The following is a description of a gene set: species: Mus musculus Mouse Gene Set: MIR_6935_5P from publication Chen Y, Wang X (PMID 31504780) Genes predicted to be targets of miRBase v22 microRNA mmu_miR_6935_5p in miRDB v6.0 with MirTarget v4 prediction scores > 80 (high confidence targets)., and this is the list of marker genes: Brpf3, Plpp6, Ppp4c, Limch1, Fam89b, Tbr1, Xylt2, Slco1a5 (NCBI Gene Id 28245), Eya1, Atg10, Marf1, Vash2, Acsf2, Grb10, Sfmbt2, Cntn4, Ttc7, Vps25, Slc2a4, 4933428G20Rik, Kdm2a, Zmiz1, Lyl1, Ezh1, Bptf, Tbc1d14, Krtap4-2, Cd37, Fbxw9, Yif1b, Bbln, Pklr, Shisal1, Atf6, Myef2, Fam53c, Git1, Mbnl3, Hpcal4, Acer2, Trpc3, Phc2, Tcte1, Psg21, Prss32, Wars1, Grik3, C2cd2l, Dnajb13, Gm867, Igf2bp2, Dagla, Psg22, Xirp1, Scn4b, Fev, Gars1 (glycyl-tRNA synthetase 1), Wnt1, St8sia6, Cry2, Ttc9, Cyp4v3, Dlg4, Ywhaz, Psg26, Krtap4-6, Ldb3, Brcc3, Ctsw, Sftpa1, Tnfsfm13, Trp53inp2, Psg19, Cdk6, Psg17, Adamts17, Ap1g1, Slc26a5, Arhgef2, Adcyap1r1, Me3, Gria2, Hnrnpu, St8sia3, Gjc3, Htra3, Stk35, Dtna, Psca, Gpr149, Trnp1, Ptp4a1, Iqsec3, Reln, Atxn1l, Cp, Tnfsf13, Pmm2, Khnyn, Parp11, Dapl1, Nr6a1, Cyp2c55